Given this list of marker genes CNR1, KCNJ15, NFE2L3, MSRB2, NBPF3 (NCBI Gene Id 84224), SLC35E2B, MYOCD, MGAT2, TNS1, AHCYL1, WDR89, RGS6, KAT6B, DOCK5, SMPD3, EEF2, MBD5, SIRT3, NFIB, YARS2, NBPF20, RPS6KB1, ZBTB41, UBE2F, SLC35E2A, KLF9, HCAR1 (hydroxycarboxylic acid receptor 1), AGO4, SMG1, NBPF12, CD163L1, ADAMTS13, FAM167A, ZBTB8B, USP49, CCDC80, IGSF10, DMRTC2, NBPF11, TMEM64, SIKE1, LDAH, ATP2A2, ACSL5, NBPF1 (NCBI Gene Id 55672), TMEM74, SFR1, NBPF15, GPT2, ZFP41, DUSP19, KIF2B, RAP1GDS1, GLCCI1, ZNF577, PPP4R1 (NCBI Gene Id 9989), GATA6, PDGFRA, PIWIL1, PRSS55, SEC11C, ELAVL1, WNK1, XPO4, ZCCHC2, CREB5, STYXL1, ETF1, KCNB1, SART3, KCNK10, GRP, TBX3, SERPINB3, ITGB1BP2, NBPF14, KRTAP4-12, TXNRD1, TBC1D16 (TBC1 domain family member 16), TNK1, CLINT1, DAB2, PI4K2B, IQCH, SLC25A27, PPM1B, SH3D19, CALHM5, LPIN2, SPTLC3, ERBB4, NEDD4L, NBPF8, ORC5, ZBTB34, PCDH17, ACE2, FBXW7, MMD2, FYB2, NAPB, THSD7A, GDA, NPLOC4, ATCAY, SIGLEC6, GUCY1A2, CYSTM1, NBPF9, CEBPB, ZNF652, SH3PXD2A, NSF, ANKRD29, SUDS3 (SDS3 homolog, SIN3A corepressor complex component), BNC2, FAM83B, WEE2, NPM1 (nucleophosmin 1), HS2ST1, NECAB1, ONECUT2, RO60, PIGA, SCAPER (S-phase cyclin A associated protein in the ER), CLEC4F, here is a description of the gene set: from publication Chen Y, Wang X (PMID 31504780) species: Homo sapiens Human Gene Set: MIR4520_2_3P Genes predicted to be targets of miRBase v22 microRNA hsa-miR-4520-2-3p in miRDB v6.0 with MirTarget v4 prediction scores > 80 (high confidence targets).